The following is a description of a gene set: Mouse Gene Set: chr11A5 studied in species Mus musculus, and this is the list of marker genes: Atp10b, Gm12146, Gm12140, Gabra1, Tenm2 (NCBI Gene Id 77515), Gm22127, Gm12129, 3110004A20Rik, A230004M16Rik, Btf3-ps7, Hmmr, Gabrg2, Gm12136, Gm12130, Gm12134, Gabrb2, Gabra6, Gm24446, Gm9972, Gm24192, Gm12132, Gm12128, Gm12138, Nudcd2, Mat2b, Platr13, Hmgb1-ps1, Hspd1-ps3, Ccng1, Gm12133